Given this list of marker genes Parp8, Snx4, Gm11780, Ube3a, Dcun1d1, Abca8b, Sike1, Wdr11, Actn1, Cep350, Tmem209, Zfp131, Car5b, Pcdh7, Slc41a2, Hectd4, Sema3d, Gpr141b, Rnf14, Ppargc1a, Clrn3, Pdlim5, Tmed5, Napepld, Luzp2, Rsf1, Catsperb, Pde7b, Neo1, B4galnt2, Mkrn2os, Timp2, Shf, Ccdc88a, Lin9, Rap1b, Zfp37, Gabrg1, Csgalnact2, Cxcl15, Pappa2, Adcyap1, Zbtb41, Vwc2l, Ahdc1, Ythdf1, Atxn1, Gtpbp1, Cemip, Ust, Tanc2, Lrrtm3, Nkx2-2 (NCBI Gene Id 228734), Anln, Rbm27, Spin4, Rbm41, Pde10a, Slamf7, Slit3, Kctd4, Slc24a2, Rgs7bp, Tpmt, Zng1, Apobec4, Syde2, Kansl1l, Hapln1, Esyt2, Mpdz, Fut9, Zswim6, Nhlrc2, Vstm2a, Mmp14, Sntg1, Ccdc112, Acvr2b, Helz2, Hoxa1, Mecp2, Ppm1e, Fsbp, Edar, Prdm1, Arcn1, Tacc1, Eif2s2, Tle4, Cdc42bpb, Pitx2, Trappc10, Rgs18, Epb41l5 (NCBI Gene Id 98492), Cldn17, Numb, Cibar1, Tfdp1, Trnt1 (tRNA nucleotidyl transferase, CCA-adding, 1), Tom1l1 (target of myb1-like 1 (chicken)), Vcan, Acyp2, 1110004F10Rik, Smarcad1, Trim23, Col13a1, Tbx4, Rfx7, Dcaf10, Pard6b, Dmrta1, Hr, Lamp3, Washc4, Rnf214, Shank3, Foxd2, Tet3, Eif5a2, Manea, Pde4dip, Plpp3, Chd7, Prrg1, Trappc8, Nin, Abat (NCBI Gene Id 57428), Fundc2, Mfap3l, Chordc1 (NCBI Gene Id 66917), Ascl1, Cngb3 (cyclic nucleotide gated channel beta 3), Frmpd4, Plk2, Setd2, Lca5, Tmc7, Dmxl1, En1, Slc30a4, Nfyb, Ccdc126, Kcnj13, Nek7, Kif20a, Zdhhc5, Fam222b, Srpk2, Qrfpr, Lipo2, Snx16, Odf2l, Faf2, Crispld1, Srsf7, Atp6ap2, Ccr1, Ric1, Shld2, Tmem47, Taf5l, Pacc1, Pter, Cadm2, Gnb2, Abra, Luc7l, Hsdl2, Eea1, Dipk2a, Tnrc6a, Nipbl, Brcc3, Olfm3, Hoxd13, Gadd45a, Rora, Map4k3, Ocrl, Ccdc85b, Frrs1l (NCBI Gene Id 230235), Fhdc1, Slc35a5, Hoxa10, Arih2, Onecut2, Rfx4, Celf4, Cpox, Ccne2, AI593442, Elf1, Mkx, Iqsec2, Sp4, Gucy1a2, Myt1l, Zfp277, Fnip1, Syt1, Zfp280d, Armcx5, Wnt5b, Bola3, Tmem108, Ttll7, Hunk (NCBI Gene Id 26559), Rdh14, Pde4b, Kat6a, Cd247, Ccl28, Hspa4, Med13, Scai, Ythdf2, Gm5431, Smad6, Homer1, Ntf3 (NCBI Gene Id 30909), Il22b, Hectd1, Lpar1 (lysophosphatidic acid receptor 1), Shisa6, Slco2a1, Myo5c, Relch, Adam10, Fgl2, Shank2, Dcaf6, Crim1 (NCBI Gene Id 50766), Bsdc1, Dcaf1, Hes1, Pfkfb2, Hyal6, Mapk6, Gabrg2, Dusp8, Slc25a46, Kctd19, Lrrtm2, Lrch1, Cand1, Nxf3 (nuclear RNA export factor 3), Zfp383, Lin54, Mtrex, Rad21, Arid4a (NCBI Gene Id 320602), Ralgds, Stim2, Slf1, Wfdc12, Galnt11, Gimap8, Zfp712, Saxo2, Wnt5a, Gabpb1, Loxl4, Il12a, Ppwd1, Gpr141, here is a description of the gene set: Genes predicted to be targets of miRBase v22 microRNA mmu_miR_374b_5p in miRDB v6.0 with MirTarget v4 prediction scores > 80 (high confidence targets). Mouse Gene Set: MIR_374B_5P species: Mus musculus from publication Chen Y, Wang X (PMID 31504780)